The following is a description of a gene set: CD8 T cells normally differentiate from resting naïve T cells into function effector and then memory CD8 T cells following acute infections. During chronic viral infections, however, virus-specific CD8 T cells often become exhausted. We used microarrays to examine the gene expression differences between naive, effector, memory and exhausted virus-specific CD8 T cells following lymphocytic choriomeningitis virus infection. Genes down-regulated in comparison of naive CD8 T cells versus exhausted CD8 T cells. studied in species Homo sapiens from publication Wherry EJ, Ha SJ, Kaech SM, Haining WN, Sarkar S, Kalia V, Subramaniam S, Blattman JN, Barber DL, Ahmed R (PMID 17950003) Human Gene Set: GSE9650_NAIVE_VS_EXHAUSTED_CD8_TCELL_DN, and this is the list of marker genes: GPM6B, UQCC5, TRPC6, SLX9, ACADVL, ID2, IKZF4, FHL1, TGM2, ZNF436, TMEM150A, VAMP5, CELF4, VMP1, ATF6, SHMT2, IL10RA, BNIP2, CYP2A6, EOMES, CRISP2, TNNI1, MYO6, GDAP1, H1-4, S100A13, HMX3, FJX1, PBDC1, IL1A, ACSL1, CRYBB2, ETV1 (ETS variant transcription factor 1), YAP1, PRDM1, IMMT, PRXL2A, CCL5, HMGA2, AFP, AHNAK, TM4SF1, PCLO, PERP, COPRS, BRS3, GZMB, RHAG, VAMP7, HINFP, CFH, KCTD9, GEM, AGAP1, TCTA, TNFRSF9, RASGRF2, EEA1, CD244, CXCR3, TUG1, POLD2, SERPINB2, PTPN12, EFHD2, LRP10, SUB1, SNRNP27, MYRF, NDUFA13, CCDC47, CIT, XCR1, PHF7, MYCL, SLC4A7, BAAT, DPP7, MRPL17, SYPL1, ST6GALNAC2 (NCBI Gene Id 6488), DUSP8, SCAND1, H3C7, RNF123, PHLDB2, HASPIN, PRRC1, ENTPD7, ADAM7, DPT, RPA2, TRPC1, TMEM266, KGD4, FRMD5, AUH (AU RNA binding methylglutaconyl-CoA hydratase), LCN2, MYO1F, CHL1, MYH4, PTPRJ, CRYZ, PARP1, CKMT2, HCFC1R1, TNFSF10, SPOCK2, HOXC6 (homeobox C6), GNPTAB, GSTM1, ADA (adenosine deaminase), RBM15, CTLA4, DMAP1, CPA3, SCN7A, TLR7, MRPS18A, COCH, TERF1, KHK, CSRP1, CCDC93, KLRK1, CIZ1, HCN1, LITAF, NELFE, TLN1, GDNF, RPS14, TNKS1BP1 (tankyrase 1 binding protein 1), COL19A1, KCNAB1, SASH1, OSBPL9, ATP5MF, EPHB6, EIF2AK2, CCR5, BOP1, CORO2B, MMP14, AOPEP, RAB33B, SERPINH1, EPCAM, MOCOS, STX3 (syntaxin 3), HOXD10, CANX, MITF, F2RL1, TJP1, ANXA3, ARG1, BCL2A1, F2R, PLSCR1, SYT1, EFNB3, H1-5, TBX15, GTF3C4, CISH, MRPS2, TNFRSF1A, H2BC5, HTR2C, FASLG, RELN, NQO1, CLDN11, CSF1, PAWR, CCRL2, STRA6, TPK1, CLCA1, BHLHE40, ZNF821, RGS16, GSTM3, IFNG, CCN3, GJA1, DPY30, LPP-AS2, SCRG1, CTSE, POLR2C, KRT27, ZNF35, MAP2, CLIC4, MRPL48, LAMC1, DOCK7, SEC14L1